Given this list of marker genes SLC36A1, SLC36A2, here is a description of the gene set: Reactome Pathway: Proton-coupled neutral amino acid transporters studied in species Homo sapiens part of: SLC-mediated transport of amino acids The human SLC36A gene family encodes four proton-coupled neutral amino acid transporters, PAT1-4. PAT1 and 2 mediate electroneutral symport of protons and small neutral amino acids like glycine, alanine and proline. PAT3 and 4 are orphans with unknown function (Boll M et al, 2004).